Given this list of marker genes RBPJ, MSX2, ENG, ACVR1, HEY1, WNT16, BMP4, TWIST1, SPRY1 (sprouty RTK signaling antagonist 1), NOG, PDCD4, TGFB2, TGFB3, SMAD4, OLFM1, EFNA1, HEY2, TGFBR2, NOTCH1, TGFBR3, TMEM100, FGF8, RTN4, JAG1, SNAI2, MIR19A, MIR19B1, WNT2, TGFB1, MSX1, BMP2, MIR21, TBX3, ADAM15, SNAI1, EMP2, HAS2, HEYL, ACVRL1, TGFBR1, here is a description of the gene set: Human Gene Set: GOBP_CARDIAC_EPITHELIAL_TO_MESENCHYMAL_TRANSITION studied in species Homo sapiens A transition where a cardiac epithelial cell loses apical/basolateral polarity, severs intercellular adhesive junctions, degrades basement membrane components and becomes a migratory mesenchymal cell.